The following is a description of a gene set: from publication Chen Y, Wang X (PMID 31504780) Genes predicted to be targets of miRBase v22 microRNA mmu_miR_101c in miRDB v6.0 with MirTarget v4 prediction scores > 80 (high confidence targets). Mouse Gene Set: MIR_101C species: Mus musculus, and this is the list of marker genes: Rpl39, Sorbs1, Rxrb, Flrt2, Meioc, Pwwp3b, Acvr2b, Ccdc43, Ccpg1 (NCBI Gene Id 72278), Mycn, Evi2b, Maea, Ccny, Col8a1, Ddx5, Zfp804a, Sh3pxd2a, Npnt, Ugt8a, Pitpnb, Ep300, Cdyl, Rad23b (NCBI Gene Id 78352), Cbx7, Armc2, Sult4a1, Nek7, Capn6, Tmem121b, Ormdl1, Eya1, Thoc1, Mtdh, Pxmp4, Atrx, Kcnj6, Terb1, Adamts17, Llgl1, Gcc2, Neb, Sf3b6, Tram1, Myo5a, Cacnb4, Zfp367, Ndfip1, Slc31a2, Pnkd, Rap2a, S100g, Map3k2, Npy1r, Tenm3, Capn8, Gja1, Cpeb3, Hacd3, Emp1, Jam3, Tal1, Cnst, Chrnb4, Atxn1, Zcchc9, Hoxa5, Ifi44l, Glb1l3, Sh3glb1, Crym, Numb, Bicd2, Lnpk, 1110032F04Rik, Tet2, Ezh2, Tead3, Acadm